The following is a description of a gene set: Mouse Gene Set: GOBP_REGULATION_OF_BMP_SIGNALING_PATHWAY studied in species Mus musculus Any process that modulates the frequency, rate or extent of the activity of any BMP receptor signaling pathway., and this is the list of marker genes: Bmp4, Eng, Gata6, Pparg, Gata4, Gpc3, Rbpms2, Chrd, Smurf2, Lrp2, Fstl5, Fstl3, Lemd3, Msx2, Fbxl15, Sfrp4, Cer1, Fkbp8, Cav1, Fst, Itga3, Gdf5, Rbpj, Sox11, Tmem53, Skor1, Hjv, Htra1, Gdf2, Dkk1, Erfe, Tnfaip6, Hipk2, Skil, Prmt1, Nbl1, Smad2, Kdr (kinase insert domain protein receptor), Ngly1, Foxd1, Wnt5a, Crim1, Numa1, Chrdl2, Tob1, Ccn1, Sorl1, Ppm1a, Vwc2, Acvrl1, Vwc2l, Scube3, Gpr155, Sfrp1, Wnt1, Kcp, Dand5, Dlx1, Tbx20, Crb2, Smad7, Nog, Tfap2b, Mtmr4, Hoxa13, Gdf3, Pelo, Skor2, Nanog, Tcf7l2, Grem1, Hes1, Fzd1, Abl1, Smad6, Grem2, Htra3, Fstl1, Fstl4, Msx1 (NCBI Gene Id 269644), Notch2, Vsir, Cdh5, Ilk, Sfrp2, Sostdc1, Rgma, Bmper, Mir675, Sost, Bambi, Chrdl1, Elapor2, Fbn1, Ctdspl2, Sulf1, Twsg1, Ube2o, Spart, Tgfbr3, Zfp423, Trim33, Tmprss6, Lemd2, Ark2c, Notch1, Hes5 (NCBI Gene Id 15208), Ski, Smurf1, Neo1